The following is a description of a gene set: from publication Lee MS, Hanspers K, Barker CS, Korn AP, McCune JM (PMID 15210650) studied in species Homo sapiens Genes up-regulated in naive CD4 T cells from cord blood versus thymic stromal cells. Human Gene Set: GSE1460_NAIVE_CD4_TCELL_CORD_BLOOD_VS_THYMIC_STROMAL_CELL_UP Subpopulations of human fetal thymocyte and circulating naïve T cells were obtained through FACS sorting, including CD3-CD4+CD8- intrathymic T progenitor cells (ITTP), CD3intCD4+CD8+ \double positive\ thymocytes (DP), CD3highCD4+CD8- \single positive\ thymocytes (SP4), CD3+CD4+CD8-CD45RA+CD62L+ naive T cells from cord blood (CB4+), and CD3+CD4+CD8-CD45RA+CD62L+ naive T cells from adult blood (AB4+)., and this is the list of marker genes: TTC21B, SYNE2, H1-3, FAM53B, SPINK4, IL24, TAOK1, SIK3, RPS2, GPX2, UBA7, PDE4B, PRL, TP73, L2HGDH, IFNAR1, MPIG6B, KLHDC8A, FAIM2, PIGZ, TIMM50, HERC2, NSFL1C, MFNG, C6orf47, CELSR2, PBX2, DLX4, PCBP2, RPL23AP32, RPL10A, FFAR3, PAX4, NAT10 (NCBI Gene Id 79715), CCNK, PMS2P1, CRLF3, XRCC2, AGXT, CASZ1, RFX5, DCHS2, GNMT, IDH3B, ENGASE, SERINC5, SPDEF, XKR8, BIN1, SPTBN2, SUPT20H, MAN1C1, ARNT, CLPS, PDGFB, TDRD3, ANKZF1, HR, CHRM4, MEGF6, RPL31, RANBP10, SEC31B, ZC3H12A, INSRR, PMS2P3 (NCBI Gene Id 5387), RPS6KB2, IFIH1, EPB41L4A-DT (EPB41L4A divergent transcript), MAPKAPK3, SPPL2B, SYN3, CHMP7, MPHOSPH8, LMBR1L, MIS12, CLEC2B, MCCC1, DGKA, IL1RN (interleukin 1 receptor antagonist), PCDHB11, PIP5K1B, LRRFIP1, HABP2, CACNA1D, IRF2, WAS, RPS4X, TNFRSF9, TRAPPC14, MX2, ST7L, NRDC, ERICH1, C22orf31, MINDY1, RPL9, ATP11A, DNAH17 (dynein axonemal heavy chain 17), PPP6R1, ZDHHC13, C2orf68, PRR36, MBL1P, MAPKAPK5-AS1, GRM2, IL17RC, GABRA3, KRT2, RAD54L2, TBXT, ZNF34, CORO2A, NME3, PHF11, AZU1, KLK6, P2RY4, MLC1, NPY4R, TRIM14, KLK12, BCL2L10, ZFR2, ZNF646, DKKL1, MTNAP1, PRKX, WNT16, MAP3K11, TNFSF14, TSC22D3 (NCBI Gene Id 64477), DAP3, KLC2, ERAP1, BST2, MAP6D1, INF2, VGF, VAMP2, PLAAT2, FZD8, PES1, RAD9A, THADA, ABCC2, JCHAIN, ZNF75D, RNMT, ADA2, GPRASP1, TMEM131L, GLE1, GCAT, RSAD1, TRMT2B, SEC14L2, PITX3, PSMF1, EPHX2 (epoxide hydrolase 2), SLC44A1, BMP8B, WNT6, TERT, RCC1, SCYL3 (SCY1 like pseudokinase 3), ELOA-AS1, DHX8, ARRB1, AAK1, RPGRIP1, H2BC17, EIF3D, VGLL1, NOP53, HMX1, ZNF266, DNAH9, CES2, CDKL2, PIGR, PCSK7 (NCBI Gene Id 95070), CAMKK2, USPL1, PIK3C2B, APBA3, CC2D1A, GAP43, PPY2P, FBXO24, GFAP, PCYOX1L, CEP152